The following is a description of a gene set: species: Mus musculus A homeostatic process involved in the maintenance of a steady state level of potassium ions within a cell. Mouse Gene Set: GOBP_INTRACELLULAR_POTASSIUM_ION_HOMEOSTASIS, and this is the list of marker genes: Atp1a2, Fxyd2, Atp1b1, Atp1a3, Kcnma1, Camk2d, Atp4b, Slc12a2, Atp1b2, Atp1a4, Kctd7, Bsnd, Atp1a1, Atp4a, Atp12a, Atp1b3